The following is a description of a gene set: The directed movement of a nucleotide, any compound consisting of a nucleoside that is esterified with (ortho)phosphate, into, out of or within a cell. Human Gene Set: GOBP_NUCLEOTIDE_TRANSPORT studied in species Homo sapiens, and this is the list of marker genes: LRRC8A, SLC17A9, SLC25A42, PANX1 (pannexin 1), CALHM2, SLC25A51, SLC25A41, SLC25A4, ADCY10, SLC25A53, SLC35B1, P2RX7, LRRC8C, SLC25A31, SLC25A6, EPG5, ABCC4 (NCBI Gene Id 10257), CALHM3, SLC25A33 (solute carrier family 25 member 33), ABCC11, CALHM6, CALHM4, CALHM1, SLC35B3, CR1, LRRC8D, LRRC8B, SLC25A47, SLC25A52, ABCC1, SLC25A25, SLC25A23, SLC25A32, CD47, SLC25A5, SLC25A17, SLC35B2, ANKH, SHOC2, ABCC5, SLC46A2, SLC19A1 (NCBI Gene Id 6573), SLC25A24, SLC25A36, CALHM5, LRRC8E, ABCC6, SLC25A19